Given this list of marker genes Iqcg, Ttc12, Dnah1, Pdcl2, Mns1, Armc2, Ttll1, Spef2, Cfap44, Drc7, Cfap47, Tpgs1, Cfap97d1, Cep131, Spag6, Cfap43 (NCBI Gene Id 74924), Lrrc46, Pla2g3 (NCBI Gene Id 237625), Cfap69, Cfap206, Tbc1d21, Meig1, Cfap58 (NCBI Gene Id 381229), Ttll5, Cfap65, Spag16, Spag6l (NCBI Gene Id 50525), Neurl1a, Ift88, Cfap157 (NCBI Gene Id 227736), Zmynd12, Fsip2, Bbs2, Ube2b, Bbof1, here is a description of the gene set: species: Mus musculus The assembly and organization of the sperm flagellar axoneme, the bundle of microtubules and associated proteins that forms the core of the eukaryotic sperm flagellum, and is responsible for movement. Mouse Gene Set: GOBP_SPERM_AXONEME_ASSEMBLY